The following is a description of a gene set: Human Gene Set: HP_CHRONIC_PULMONARY_OBSTRUCTION studied in species Homo sapiens Chronic pulmonary obstruction An anomaly that is characterized progressive airflow obstruction that is only partly reversible, inflammation in the airways, and systemic effects or comorbities., and this is the list of marker genes: HLA-DPB1 (major histocompatibility complex, class II, DP beta 1), RSPH9, WIPF1, THSD4, NCF4, UFD1, NCF2, CTLA4, RSPH3, MCIDAS (multiciliate differentiation and DNA synthesis associated cell cycle protein), ALMS1, SERPINA1, RAC2, TBX1, PRTN3, GLA, PTPN22, CYBA, RREB1, JMJD1C, NFKB1, ARVCF (ARVCF delta catenin family member), RSPH1, HLA-DPA1, COMT, CYBB, GP1BB, CYBC1, SEC24C, HIRA, NCF1, HMOX1, CARMIL2 (capping protein regulator and myosin 1 linker 2), DNAAF4, MPEG1, BLM, WAS (WASP actin nucleation promoting factor)